Given this list of marker genes TMEM215, ZFP14, BCDIN3D, HTR4, SETD7, FAM3C, SP7, LRRTM2, ID1, ANXA7, ARFGEF2, SOCS6, CIAO2B, PTER, THOC2, CFAP300, ATP2C2, PLXNC1, TEX30, DCLK3, HNRNPDL, RPS6KA6, GLCE, TMEM68, PLP1, CTCFL, PTPRR, PAK3, WIF1, PLCB1, SDHAF3, MFAP3L, ATG3, GIPC2, TLK2, ZCCHC7, LIMS2, MAP3K1, MSANTD2, INSIG2, CDC42SE2, ENY2, TBC1D32, KCND2, ENC1, MYH10, SLC25A40, MAPK8, GRHL2, STT3B, PPM1E, TNFSF14, RAB18, MLEC, MPHOSPH8, CYP24A1, FAM120A, ULK4, GOLGA7, MBNL3, FGF7, PTCHD4, GUCY1A2, SYNPO, LILRB4, SLC11A2, TRNT1, TNPO2, HNRNPF, CFL2, here is a description of the gene set: species: Homo sapiens Human Gene Set: MIR4289 Genes predicted to be targets of miRBase v22 microRNA hsa-miR-4289 in miRDB v6.0 with MirTarget v4 prediction scores > 80 (high confidence targets). from publication Chen Y, Wang X (PMID 31504780)